The following is a description of a gene set: species: Homo sapiens Reactome Pathway: MET activates PTK2 signaling MET receptor activates the focal adhesion kinase PTK2 (FAK1) in a process that depends on the simultaneous interaction of PTK2 with integrins and with MET. SRC is needed for PTK2 to become fully active. Activation of PTK2 is needed for HGF-induced cell motility. part of: MET promotes cell motility, and this is the list of marker genes: LAMB1, LAMC1, COL5A1, LAMA4, MET, COL3A1, LAMC3, ITGA3, COL27A1, COL1A1, COL11A1, LAMA2, LAMA3, LAMA1, LAMB3, COL5A3, SRC, FN1, COL2A1, COL24A1, ITGA2, ITGB1, COL1A2, PTK2, HGF, LAMC2, COL11A2, LAMB2, LAMA5, COL5A2